The following is a description of a gene set: Mouse Gene Set: GOBP_REGULATION_OF_NON_CANONICAL_NF_KAPPAB_SIGNAL_TRANSDUCTION Any process that modulates the frequency, rate or extent of the non-canonical NF-kappaB signaling cascade. species: Mus musculus, and this is the list of marker genes: Rc3h2, Lrrc19, Rtkn2, Crebbp, Nod2, Rc3h1, Ccl19-ps5, Map3k7, Uaca, Birc2, C1qtnf3, Prdx1, Nlrp3, Ago1, Tlr2, Hmgb1, Trim15, Ppm1b, Trim56, Adipor1, Ago3, Terf2ip (telomeric repeat binding factor 2, interacting protein), Ccl19-ps4, Ptp4a3, Cyld, Il18, Tnfsf14, Cd86, Nlrp12, Trim55, Il1b, Calr, Nmi, Cpne1, Capn1, Hdac7 (NCBI Gene Id 56233), Edn1, Vcp, Nlrc3, Rps3, Rela, Rbck1, Trem2, Ifi35, Ccl19, Sash1, Ccl19-ps6, Adissp (NCBI Gene Id 67326), Fbxw11, Eif2ak2, Pdcd4, Laptm5, Nol3, Bcl3, Tek, Mkrn2, Rassf2, Tlr7, Nod1, C1qtnf4, Phb1, Edaradd, Tlr4, Adgrg3, Sphk1, Tlr9, Ccl19-ps1, Ndufc2, Ccn3, Ppm1a, Zc3h12a, Il18r1, Smpd3 (sphingomyelin phosphodiesterase 3, neutral), Actn4, Tlr3, Akip1, Nr3c2, Tcim (transcriptional and immune response regulator), Lime1, Havcr2, Phb2, Pycard, Spi1, Tnf (tumor necrosis factor), Egfr, Ddx3x, Ager, Ank3, D1Pas1, Litaf (LPS-induced TN factor), Ccl19-ps3, Trim44, Birc3, Edar, Ripk1, Grem1, Trim60, Trim26, Trip6, Ptpn22, Eda, App